Given this list of marker genes SERPINB5, MYC, ATF4, BACE2, PDE2A, ELF3, HNRNPH1, TSC22D3, KRT14, SYNCRIP, ANPEP, RASL12, here is a description of the gene set: Genes up-regulated in HeLa cells (cervical carcinoma) 24 h after infection with adenovirus Ad12. studied in species Homo sapiens from publication Dorn A, Zhao H, Granberg F, Hösel M, Webb D, Svensson C, Pettersson U, Doerfler W (PMID 15681441) The infection of human cells by adenoviruses leads to a gradual reduction in the activity of host cell functions while viral gene expression progresses in a regulated way. We used the DNA microarray technique to determine the transcriptional activity profiles of cellular genes upon infection with adenovirus type 12 (Ad12). The microarray data were validated by quantitative real-time PCR for genes which showed significant alterations after Ad12 infection. At 12 h postinfection, there is a striking up-regulation between 10- and 30-fold in the expression of the G1P2, IFIT1, and IFIT2 cellular immune response genes compared to mock-infected cells. At later stages of infection, when the majority of regulated cellular genes has been turned down, a limited number of cellular genes exhibit increased activities by factors of 3 or less. These genes belong to the signal transduction or transcriptional regulator classes or are active in protein degradation, like ANPEP, an aminopeptidase. The SCD and CYP2S1 genes function in lipid metabolism. The eucaryotic translation initiation factor 4 is up-regulated, and one of the major histocompatibility complex genes is diminished in activity. For two of the genes, one up-regulated (CTSF gene) and one down-regulated (CYR61 gene), alterations in gene activity were confirmed at the protein level by Western blotting experiments. Increased genetic activity of cellular genes late in adenovirus infection has not been reported previously and demonstrates that Ad12 has a sustained control of host cell gene expression well into the late phase of infection. Human Gene Set: DORN_ADENOVIRUS_INFECTION_24HR_UP